The following is a description of a gene set: Human Gene Set: GOBP_MAINTENANCE_OF_CENTROSOME_LOCATION studied in species Homo sapiens Any process in which a centrosome is maintained in a specific location within a cell and prevented from moving elsewhere., and this is the list of marker genes: AKAP9, GPSM2, PAFAH1B1, SPOUT1, TBCCD1, ASPM